The following is a description of a gene set: Mouse Gene Set: CUI_T_CELL_CD4_IL17E_RESPONSE_UP from publication Cui A, Huang T, Li S, Ma A, Pérez JL, Sander C, Keskin DB, Wu CJ, Fraenkel E, Hacohen N (PMID 38057668) species: Mus musculus Genes positively differentially expressed in cell type: CD4+ T cell upon treatment with cytokine: IL-17E in mouse lymph nodes in vivo. Cytokines mediate cell-cell communication in the immune system and represent important therapeutic targets. A myriad of studies have highlighted their central role in immune function, yet we lack a global view of the cellular responses of each immune cell type to each cytokine. To address this gap, the authors created the Immune Dictionary, a compendium of single-cell transcriptomic profiles of more than 17 immune cell types in response to each of 86 cytokines (>1,400 cytokine-cell type combinations) in mouse lymph nodes in vivo. A cytokine-centric view of the dictionary revealed that most cytokines induce highly cell-type-specific responses. For example, the inflammatory cytokine interleukin-1β induces distinct gene programmes in almost every cell type. A cell-type-centric view of the dictionary identified more than 66 cytokine-driven cellular polarization states across immune cell types, including previously uncharacterized states such as an interleukin-18-induced polyfunctional natural killer cell state., and this is the list of marker genes: Cd3e, Ifi27l2a, Tmsb10, Ly6a, Pfn1